The following is a description of a gene set: Catalysis of the transfer of a phosphate group to a histone. Human Gene Set: GOMF_HISTONE_KINASE_ACTIVITY studied in species Homo sapiens, and this is the list of marker genes: VRK1, PRKCB, DCAF1, CDK1, JAK2, PRKCA, ATR, PKN1, ATM, PRKAA1, PKM, CHEK1, RPS6KA5, HIPK4, BAZ1B, RPS6KA4, PRKAA2, PRKDC, DYRK1A, BUB1, CDK2, HASPIN, AURKA (aurora kinase A), MAP3K7